The following is a description of a gene set: studied in species Mus musculus Any process that results in a change in state or activity of a cell or organism (in terms of movement, secretion, enzyme production, gene expression, etc.) as a result of a human chorionic gonadotropin stimulus. Mouse Gene Set: GOBP_RESPONSE_TO_HUMAN_CHORIONIC_GONADOTROPIN, and this is the list of marker genes: Gclc, Gclm, Gjb2, Edn1, Ednra, Foxl2